The following is a description of a gene set: Reactome Pathway: RAF/MAP kinase cascade studied in species Mus musculus part of: MAPK1/MAPK3 signaling This event has been computationally inferred from an event that has been demonstrated in another species.<p>The inference is based on the homology mapping from PANTHER. Briefly, reactions for which all involved PhysicalEntities (in input, output and catalyst) have a mapped orthologue/paralogue (for complexes at least 75% of components must have a mapping) are inferred to the other species. electronically inferred by orthology from the curated human pathway, and this is the list of marker genes: Sptbn2, Rgl1, Pebp1, Grin2d, Dusp6, Psmd7, Ppp2r5d, Dusp5, Shoc2, Grin2b, Pdgfa, Rasa1, Ret, Il2rg, Fgf1, Jak3, Dusp7, Il5, Grb2, Pik3cb, Flt3l, Ranbp9, Rasgrp4, Fgf17, Csf2rb, Irs1, Gfra1, Rasa4, Ubb, Fgf15, Ppp2r1b, Fgf10, Areg, Rps27a, Dlg3, Abhd17c, Map2k2, Il3, Psmc3, Rasgef1a, Bcl2l1, Ptpn3, Ppp2r5b, Rasal3, Fgg, Arrb2, Ksr2, Phb1, Gdnf, Irs2, Zdhhc9, Psma6, Calm1, Psmb5, Psma7, Ppp2r5a, Psma2, Psma5, Pdgfrb, Psmc4 (proteasome (prosome, macropain) 26S subunit, ATPase, 4), Il2, Mapk12, Dusp2, Spred3, Sptbn4, Frs2 (fibroblast growth factor receptor substrate 2), Fgf5, Epgn, Fgf2, Brap, Fgf22, Itga2b, Ralgds, Fgf6, Grin1, Dusp9, Hgf, Fgf8 (NCBI Gene Id 14179), Fgfr1, Tgfa, Ppp5c, Pik3r2, Pea15a, Il5ra (interleukin 5 receptor, alpha), Fgf23, Fgf7, Fgf4, Rasgrp3, Csf2, Egfr (epidermal growth factor receptor), Psmc5, Fnta (NCBI Gene Id 14272), Erbb2, Klb, Pdgfb, Ptpra, Csk, Kitl, Rasal1, Psma4, Psmd13, Shc3, Il2rb, Rasgrp1, Psmd1, Psmd6, Btc, Mapk3, Artn, Fgf16 (NCBI Gene Id 80903), Rapgef2, Ptpn7, Rgl3, Shc1, Lypla1, Psmc6, Psmb4, Camk2b, Lat, Wdr83, Il2ra, Nrg3, Lamtor2, Dusp16, Tln1, Nefl, Psmb6, Fgf20 (fibroblast growth factor 20), Psmc1, Shc2, Psmb7, Apbb1ip, Fyn, Hras, Map2k1, Dlg4, Erbb4, Cnksr2, Kl, Psma1, Ptk2, Cnksr1, Psma3, Nrtn, Kit, Psmc2, Psmd12, Gfra2, Ncam1